Given this list of marker genes AKR1C1, ABCB11, SLC51A, AKR1D1, CYP39A1, OSBPL2, CYP46A1, AKR1C4, ACOT8, CYP7A1, SLC10A2, SLC10A1, AMACR, NCOA1, SLC51B, OSBPL1A, CYP7B1, BAAT, OSBPL3, CYP8B1, ALB, AKR1C3, SCP2, SLC27A2 (NCBI Gene Id 8523), OSBPL9 (oxysterol binding protein like 9), RXRA, ACOX2, CH25H, HSD17B4, SLCO1B1, CYP27A1, OSBP, AKR1C2, SLC27A5, ABCC3, SLCO1B3, NCOA2, STARD5, FABP6, SLCO1A2, OSBPL6, OSBPL7, NR1H4 (NCBI Gene Id 9971), HSD3B7, here is a description of the gene set: Bile acid and bile salt metabolism Human Gene Set: REACTOME_BILE_ACID_AND_BILE_SALT_METABOLISM species: Homo sapiens